The following is a description of a gene set: Abnormality of the temporal bone of the skull, which is situated at the sides and base of the skull roughly underlying the region of the face known as the temple. Human Gene Set: HP_ABNORMAL_TEMPORAL_BONE_MORPHOLOGY Abnormal temporal bone morphology studied in species Homo sapiens, and this is the list of marker genes: FGFR3, CEP57, GDF6, GDF3, POR